Given this list of marker genes RYBP, MDFIC2, COX6CP6, CCDC137P2, RNU6-1270P, PDZRN3, LINC02047, PRDX5P1 (PRDX5 pseudogene 1), LINC00877, FOXP1, MIR1284, RNU1-62P, RNU6-557P (NCBI Gene Id 106479814), ENSG00000277855, PSMD12P1, EBLN2, UQCRHP4, LAPTM4BP2, GXYLT2, RNPC3P1, UBE2Q2P9, RNU7-119P, PROK2, LINC00870, FOXP1-DT, U2SURPP1, RNU2-64P, PPP4R2, GPR27, CCDC137P1, HMGB1P36, FTH1P23, RN7SL271P, LINC02005, MTCO3P47, GPATCH11P1, PDZRN3-AS1, EIF4E3, FOXP1-IT1, MITF (NCBI Gene Id 7487), ENSG00000287131, RN7SL418P (NCBI Gene Id 106480508), FOXP1-AS1 (NCBI Gene Id 104502416), SAMMSON, SHQ1, RNA5SP136, RNU6-281P (RNA, U6 small nuclear 281, pseudogene), RNU7-19P, here is a description of the gene set: Human Gene Set: chr3p13 studied in species Homo sapiens